Given this list of marker genes PAICS, HPRT1, ADSS2, ADK, ADA, ADSS1, APRT, GART, ADSL, PPAT, NUDT2, ATIC, PFAS, here is a description of the gene set: Human Gene Set: GOBP_AMP_BIOSYNTHETIC_PROCESS studied in species Homo sapiens The chemical reactions and pathways resulting in the formation of AMP, adenosine monophosphate.